Given this list of marker genes Gtf2h2 (NCBI Gene Id 23894), Mta3, Taf1b, Mnat1 (menage a trois 1, NCBI Gene Id 320958), Chd3, Polr1g, Gtf2h5, Mta2, Hdac1, Gtf2h1, Gatad2b, Ercc3, Polr2f, Gtf2h4, Gtf2h3, Mbd3, Polr1e, Rbbp4, Ehmt2, Ubtf, Cavin1, Polr1c, Ercc2, Ccnh, Polr1h, Polr2l, Taf1d, Mapk3, Polr1f, Gatad2a, Rrn3, Ercc6, Polr1b, Polr2k, Polr1a, Polr2h, Taf1a, Polr2e (polymerase (RNA) II (DNA directed) polypeptide E), Ttf1, Rbbp7, Chd4, Taf1c, Tbp, Mta1, Cdk7, here is a description of the gene set: RNA Polymerase I Transcription studied in species Mus musculus Mouse Gene Set: REACTOME_RNA_POLYMERASE_I_TRANSCRIPTION